Given this list of marker genes CTNND1, ADAM19, JUP, ANGPTL4, CDH8, CDH11, CDH24, ADAM33, AMOT, CTNNA1, CTNNB1, here is a description of the gene set: part of: Regulation of CDH11 Expression and Function studied in species Homo sapiens Reactome Pathway: Regulation of CDH11 function Like other classical cadherins, CDH11 associates with several catenin proteins through its intracellular domain, which is thought to play a role in the establishment and regulation of adherens junctions. These catenin proteins include CTNND1 (also known as p120 catenin or delta-catenin), CTNNB1 (beta-catenin), JUP (Junction Plakoglobin, also known as gamma-catenin), and CTNNA1 (alpha-catenin).<br><br>CDH11, through its C terminus, also forms a complex with angiomotin (AMOT) isoform p80 (AMOT-2), which is implicated in CDH11-mediated cell migration and tumor cell invasiveness.<br><br>Through its extracellular region, CDH11 binds to the C terminal fragment of ANGPTL4 (Angiopoietin-like-4), commonly known as cANGPTL4, which is implicated in the regulation of wound healing. The variant isoform of CDH11 (CDH11v), an 85 kDa membrane-bound protein produced as a result of alternative splicing, can compete with the canonical CDH11 for cANGPTL4 binding.